Given this list of marker genes FYN, PAK3, EFNB3, SDCBP, EPHB1, EFNB1, SRC, PAK2, EPHB3, EPHB4, PAK1, NCK2, ARHGEF7, RAC1, EPHB6, MYL12A, GIT1, EPHB2, EFNB2, here is a description of the gene set: Ephrin signaling Human Gene Set: REACTOME_EPHRIN_SIGNALING studied in species Homo sapiens